Given this list of marker genes RAP2A, SDE2, GRID2, LRRC7, TIFAB, PGRMC2, GULP1, UBE4A, MAP9, SDC2, TOLLIP, PRP4K, TLCD4, MEX3D, KCNJ3, TMEFF2, SCAMP1, DDIT4, GPALPP1, ADH5, CFL2, EVI2A, CLCN4, TRUB1, PCDH11X, UHMK1, DENND1B, BCL11B, ADAMTS1, TMEM135, BMI1, CERS6, FAM133A, U2SURP, DOLPP1, ANKH, PPEF2, ZNF503, RGPD4, TMEM167B, ZNF486, CMPK2, SLC30A5, NUP54, TRA2B, GPD1L, CFAP44, GALNT15, PPP5C, ADAM22, C3orf38, ECPAS, DYNC1I2, CYP3A7, HECA, GPATCH11, SPOPL, CCDC179, CHST9, RHOQ (NCBI Gene Id 56679), CD163, CARF (NCBI Gene Id 95855), DUT, TTC19, RO60, CLVS2, ADAMTSL5, TRPC5, PTPRG, CAMSAP2, MTA1, ZNF680, WDR26, SEC22C, NUP160, MMD, MAST3, ANAPC1, RGPD8, SKIDA1, LRP1B, HNRNPDL, RAD54B, KL, CBFB, ODAPH, ABI3BP, ACADL, MBNL2, PITX2, PRKAA1, SYNM, TFDP3, ETF1, SLU7, MIER3, PAQR9, SANBR, ONECUT2, PDCD5, GAPVD1, IGSF3, SDF4, C21orf91, TFAM (transcription factor A, mitochondrial), SMAD5, LATS1, TRPC1, NUMB, CA8, PRELID2, C5orf24, OGFRL1, ZBTB41, CNTN1, COMMD3-BMI1, KPNA4, URI1, EPHA3, DPY19L3, ZBTB10, GCC2, UNC80, EEA1, OAZ1, DNAJB4, TBCK, RRAGD, ZNF792, BTG3, FAM221A, RGPD6, RHPN2, MIGA1, PRKAA2, SREK1, ATXN2, HIPK1, GUCY1B1, BTG2, RAB27B, MINDY2, S1PR1, RGPD5, TRAM1L1, ZNG1C, SCN8A, THSD7A, SIX4, BEND7, LPP, NTF3, C11orf87, ZDHHC15, TTC13, SPDYE1, ADAMDEC1, NR2C1, ATP1B4, PDE1C, PDZRN4, POLR2H, ADGRB3, GSTCD, PPP1R9A, SOX30, GASK1A, LNPK, CBX3, IGF2BP3, MGARP, TRIM9, FUT9, PRRC1, RBBP8, KRT28, PTP4A1, MFSD9, SFMBT1, CCNB1, ZEB2, ACBD5, IKZF2, MECP2, ZNF326, RAP1A, FLRT3, EIF2AK2, ARMCX3 (NCBI Gene Id 51566), IRAK1BP1, PHYHIPL, ASB3, MAST4, ARRDC4, EDIL3, UTP3, BNIP3, FSBP, RC3H1, ZCCHC8, SCML2, ANKRD26, ZNF492, ARSJ, UEVLD, CCNY, SPTBN1, BRWD1, ANKRD10, PIWIL3, SF3A1, WAPL, FZD3, SOX5, TMED7, MST1L (macrophage stimulating 1 like (pseudogene)), RASGRP1, MBIP, GSE1, RNF138 (NCBI Gene Id 51444), BRWD3, DEFA6, ZRANB2, ZBTB44, PROX1, MARCHF1, LMX1A, SENP1, MMUT, STXBP5, B3GALT5, AIDA, TCF12, ARID2, CRIPT, ZBTB11, HOXD13, CACUL1, STYX, DIAPH3, SRSF3, MMP16, UGT8, MFSD8, WDR47, CACNA2D3 (calcium voltage-gated channel auxiliary subunit alpha2delta 3), LCOR, BBX, LARP4, CSGALNACT2, TENT5A, ARFRP1, UBE2A, TXLNG, SMG1, HOOK3, IVNS1ABP, NOTCH2 (notch receptor 2), AFTPH, DAAM1, FAM111A, NAA30, CAPN2, FBXL3, GABRA4 (gamma-aminobutyric acid type A receptor subunit alpha4), SH3D19, WDR7, DNAJB14, ZNF608, PRPF39, GRM7, GCNT1, HOMER1, DCUN1D5, ACSL3, AK3, GRIP1, A1CF, SSR3, BTBD3, LRRTM3, CISD2, CHN1, FGL2, PLEKHH2, SERINC3, ANKRD46, SYT14, DYNC1LI2, RIC1, SECISBP2L, SPOCK3, RPS6KA5, UBA6, FZD7, SLAIN1, GFPT1, ADAM30, HMBOX1, CCP110, MBNL3 (NCBI Gene Id 55796), COL11A1, PPARG, WWP1, FZD5 (NCBI Gene Id 81561), ANGEL2, PREX2, MIER1, ZNF148, NFKB1, LMCD1, PTPRR, RETREG1, MFN1 (mitofusin 1), RFX7, MDFIC, EPB41L5, MZT1, HLTF, NUFIP2, LACTB2, MAGT1, RNF149, DUSP7, FNDC3B, RNF217, ITGB6, REV3L, LVRN, PSMC2, KLRD1, ITGAV, CPNE4, PPP1R2, ARK2N, PDE4D, CUL4A, MED4, NETO1, CSTF2T, HDAC9, POU2F1, ACVR2B, MTFR1, ZNF273, SCN3A, METTL8, CHRNA7, UGDH, PAPOLG (poly(A) polymerase gamma), MARCHF6, ALG11, MED6, MAP4K4, CCNG2, HTR2C, GABPA, SERINC5, TBCA (tubulin folding cofactor A), ZC3HAV1L, ZDHHC2, PCDH11Y, SPATA6L, MYCN, FGFR1OP2, DHRS1, ABCA5, ELL2, APPBP2, FGD4, LIN7A, PPHLN1, IGF1, AP1AR, PROK2, RICTOR, ZBTB20, RHOT1, KATNBL1, KLF8, TPM3 (tropomyosin 3), ZFAND5, SESTD1, SFT2D1, FIGN, ZNG1A, TRAM1, MIDEAS (NCBI Gene Id 91748), GOLGA6L2, GLIPR1, G3BP1, SETD2, C6orf120, GABPB1, CSNK1D, RESF1, ANKRD22, CCDC50, ZBTB25, NOTUM, SLC9A6, CLIP4, AFDN, LRRC4B, SLC7A1, ZNG1B, ME1, PAX5, GPC6, PROSER1, SUMF1, RFC3, SEC24A, SLCO5A1 (solute carrier organic anion transporter family member 5A1), NFAT5, SYT11, GATM, TP53INP1, SAMTOR, AQP3, ZNF652, CDK6, XPNPEP1, ZNG1F, RASSF8, ZNF559, NCKAP1, RAB8B, ACBD3, CEP350, GPR85 (NCBI Gene Id 54329), TMEM65, NOS2, LSAMP, MAML1, MTF1, RORA, CAMLG, CD99, SACS, MEIS2, EXOC5 (exocyst complex component 5), CTNNA3, GOPC, SYTL5, MCMDC2, CIAO2A, TNFRSF21, KIF20B, METTL6, AHSA2P, TMTC3, CLDN12, CYBRD1, GNAQ, CHST7, CNTROB, SAMD8, CFDP1, TMTC1, PCLO, FYB2, PTGFRN, NEDD4L, SRSF6, TBC1D4, FAM199X, SRI, PRKG1, SDHB, KIF24, SCARF1, NRG4, RMND5A, BOD1L1, SLC4A7, SNAP91, IRS1, STEAP2, CCDC117, ARL6IP6, FMNL2, GPD2, DIP2B, CEP57L1 (NCBI Gene Id 353369), NAV2, ACAT2, DCDC2, ATP11A, GRM5, SRP9, ZNF747, AGTR1, FNIP2, TMEM200A, FEM1C, PRKAG2, FRMD5, LCTL, GPSM2, ARL13B, ZNG1E (Zn regulated GTPase metalloprotein activator 1E), CEP120, ZDHHC21, ACTN4, WNK3 (NCBI Gene Id 65267), ZNF454, CCDC47 (coiled-coil domain containing 47), DTWD2, KLF7, NUP50, NDC1, FAM135A, C9orf40, SLC24A3, PGAM1, THEMIS, YIPF5, DUS4L, GPR155, LACTB, KLF10, RGS7BP, NAT1, SNX16, GTF3C3, JARID2, PTBP3, SCN1A, MCF2L2, BTF3L4, ZC3H11C, TMEM255A, RALA, KIAA1586, COQ6, GUCY1A2, BBS10 (Bardet-Biedl syndrome 10), C1QTNF3, ERC2, CRACD, NRXN1, PPP1R27, PRPF40A, NEGR1, RRP15, UQCRB, LANCL1 (NCBI Gene Id 10314), SPAG9, IKBIP, NDFIP2, BCL2L2, PLEKHG1, ATXN7L1, FOXG1, TRIM2, CCSER1, TPBG, here is a description of the gene set: from publication Chen Y, Wang X (PMID 31504780) species: Homo sapiens Human Gene Set: MIR559 Genes predicted to be targets of miRBase v22 microRNA hsa-miR-559 in miRDB v6.0 with MirTarget v4 prediction scores > 80 (high confidence targets).